Given this list of marker genes SLC6A5, RGS4, SLC6A14, RGS2, SLC6A20, SLC6A9, SLC6A7, here is a description of the gene set: studied in species Homo sapiens The directed movement of glycine from outside of a cell, across the plasma membrane and into the cytosol. Human Gene Set: GOBP_GLYCINE_IMPORT_ACROSS_PLASMA_MEMBRANE